Given this list of marker genes Sbf2, Fabp9, Syt2, Cyp26b1, Zfyve1, Cfl1, Rag2, Hadha, Gsdma3, Pard3, Picalm, Paqr9, Fis1, Rnf34, Plek2, Tirap, Scarb1, Appl2, Pla2g4a, Pla2g2a, Scgb1b15, Tpcn2, Hsd3b1, Svil, Apol9b, Mtm1, Gsta1, Gltpd2, Jag1, Pacsin3, Hspa2, Stam2, Nf1, Stard10 (NCBI Gene Id 56018), Traf2, Anxa9, Cyp26c1, Map1b, Osbpl8, Apoc3, Pltp, Star, Ffar2, Ing2 (inhibitor of growth family, member 2), Myo1c (NCBI Gene Id 97728), Tlr4, Cyth4, Bin1, Stard9, Bpifb2, Abca1, C2cd2l, Rufy1, Cyp4f15, Myo1b, Clint1, Asap1, Itpr2, Snx4, Ephx1, Sprr2i, Arhgap35, Ccdc88a, Esr2, Ybx2, Gramd1b, Dnm2 (NCBI Gene Id 13430), Iqgap1, Scp2 (sterol carrier protein 2, liver), Ptafr, Akr1c21, Tom1l2, Veph1, Scgb1b3, Slc9a1, Snx6, Gsdmc4, Plcb2, Hsd17b1, Blnk, Osbpl11, Apoc2, Ppara, Comp, Dnm1, Sestd1, Atp5mc3, Snx1, Hspd1, Stard8, Mark1, Thbs1, Ugt1a2, Septin5, Sprr2a3, Unc119, Arl6, Atp8b1, Scgb1b30, Apol7b, Dbt, Gstm1 (glutathione S-transferase, mu 1), Nr1h4, Wdr45b, Igtp (interferon gamma induced GTPase), Fundc2, Gbp2, Akr1b8, Syp, Sult1e1, Myof, Osbpl2, Inppl1, Igf2r, Rasgrp4, Rbp3, Unc13a, Scgb1b2 (NCBI Gene Id 57426), Btk, Ear6, Pbp2, Anxa2, Epb41, Gsdma2, Avil, Nr3c1, Arhgef5, Gstp-ps, Ly96, Wdfy1, Sh3glb1, Enthd1, Gper1, Cd81, Plekha3, Gsdme, Paqr8, Cd1d2, Lbp, Sh3gl1, Jchain, Snx10, Fnbp1, Nsfl1c, Kcnj3, Laptm4b, Prom2, Trem3, Npc2, Arhgap32, Drosha, Scgb1b27, Ghr, Dysf, Gltp, Rasa2, Dppa1, Ncf1 (neutrophil cytosolic factor 1), Dab2ip, Scube2, Rho (NCBI Gene Id 212541), Vps36, Apol7a, Tnr, Gsta5, Epn3, Tecpr1, Vdr, Pex1, Hmgcl, Adap2, Snx27, Snx2, Rara, Snx3, Adh7, Map1lc3b, Mbl2, Adh4, Rbp2, Syt6, Scgb1b7, Slc22a2, Tiam1, Ugt1a1 (UDP glucuronosyltransferase 1 family, polypeptide A1), Acadvl, Ighm, Acap2, Syt8, Ppt1, Cpne2 (copine II), Dapp1, Gstm7, Snx33, Grk5, Cln8, Gga2, Pla2g2c, Rpe65, Opn4, Vill, Myo10, Cpne9, Unc13c (unc-13 homolog C), Sec14l4, Gsdmd, Amer1, Cidea, Itpr1, Defb6, Pik3c2g, Zfyve9, Gstp2, Unc13b, Cyp4f40, Insig1, Nme2, Rasa4, Anxa4, Rnase2b, Cpne4, Stard3nl, Arap2, Apol7e, Oc90, Sgk3, Eea1, Pitpnc1, Prap1, Pld2, Gpr119, Cd1d1, Bpifb4, Epdr1, Cptp, Hsd17b10, Pitpnm1, Snap25, Cdk5r2, Arap1, Pebp1, F10, Clip3, Hspa8, Bpifa2, Selp, Anxa8, Sphk1, Fundc2b, Sh3gl3, Pgrmc1, Rapgef6, Cpne6, Gramd1a, Frmpd2, Syt7, Ffar3, Cd4, Slc38a9, Pla2g4e, Snx24, Amer3, Lyn, Sprr2e, Vil1, Atp1a1, Fchsd2, Nup62cl, Rbp1, Mag, Rbp4, Plekhf1, Tulp3, Tex2, Tec (NCBI Gene Id 21682), Fgd2, Nr5a1, Pitpnb, Bin2, Pla2g7, Shbg, Scgb1b20, Gabarapl2, Ngf, Dbil5, Apoa2, Sh3yl1, Rapgef2, Defb15, Cyp4a14, Lpar4, Apoa5, Gc, Hgs, Cpne7, Myo1e, Clec4f, Defb42, Mcoln3, Cpne1, Amph, Esrrb, Apoa1 (NCBI Gene Id 11806), Hsd3b5, Sftpd, Fzd7, Anxa3, Acbd5, Gap43, Hmgb2, Plcz1, Vcp (valosin containing protein), C2cd5, Pitpna, Fabp6, Rbsn, C3, F2, Snap91, Acbd6, Tpp1 (NCBI Gene Id 12751), Pxdc1, Oma1, Sdcbp2, Rps6kc1 (ribosomal protein S6 kinase polypeptide 1), Nfe2l1, Smo, Ninj1, Plekha4, Osbpl7, Arfip1, Tulp1, Cplx1, Spata18, Apoc2l, Psd4, Anxa1, Ninj2, Pxk, Ear1, Sidt1 (SID1 transmembrane family, member 1), Tmem199, Cyp2w1, Acadl, Snx22, Gsn, Rcsd1, Tom1l1, Snx13, Osbpl9, Stard7, Noxo1, Plekhb2, Sytl2, Krit1, Irgm2, Osbpl3, Cyp26a1 (cytochrome P450, family 26, subfamily a, polypeptide 1), Snx18, Tardbp, Hnf4a (NCBI Gene Id 15378), Tlr6, Apol9a, Or1j21, Pcyt1a, Alox8, Hsd3b8, Syt15, Pctp, Pmp2, Snx11, Id3, Kcnj1, Bpifb6, Doc2b, Uqcc3, Sytl3, Mvb12a, Arhgdia, Ear2, Gbp2b, Fabp4, Arhgap9, Actn2, Twf1 (NCBI Gene Id 19230), Bscl2, Defb3, Golph3l, Osbpl1a, Mreg, Ogt, Defb21, Mbp, Myo1g, Nr2f2, Tmem97, Defb13, Ncf4, Fermt3, Or6e1, Snx7, Cd36, Faah, Cyp4f14, Scin, Plcb1, Ttpa, Defb5, Nup35, Bad, Minar2, Sprr2a1, Ldlrap1, Apol7c, Pfn3, Vdac2, Snx31, Syt12, Golph3, Dgka, Chmp2a, Pla2g4d, Acot11, Hcn1, Sh3gl2, Cps1, Adora2a, Cpne5, Insig2, Nlrp3, Ugt1a7c, Lcn5, Ceacam2, Pfn4, Snx25, Npc1l1, Fitm2, Apoe, Anxa11, Adap1, Apol11a, Esyt3, Trpv1, Cadps, Cyth3, Rasgrp1, Tlr2, Clec4e, Rnase2a, Ear10, Apol8, Syt4, Hsd11b2, Dok7, Ugt1a9, Lpar1, Plekha5, Map3k1, Pla2g2f, Spart, Timd5, Apol6, Apob, Sytl4, Cd14, Havcr1, Deptor, Vnn1, Rufy4, Gsdmc2, Prlr, Pld1, Gbf1, Pla2g2d, Hsd3b9, Pcyt1b, Mctp2, Pram1, Ear14, Gsta13, Rora, Zranb2, Zcchc14, Plekha1, Rs1, Sprr2g, Plaat3, Abca4, Arhgap26, Agap1, Gga1, Iqgap2, Dgkb, Mtss2, Snx29, Lrat, Mppe1, Tnfaip8l3, Stard13, Cpne3, Pdia2, Prkca (protein kinase C, alpha), Osbpl10, Ucp1, Snx30, Cd55b, Acoxl, Opn5, Pirt, Fabp3, Gcdh, Bpifa1, Scap, Rlbp1, Zfyve26, Snx12, Wipi1, Bpi, Gsta2, Soat2, Prkci, Snx14, Mark2, Bcas3, Mitd1, Gpr183, Acot12 (NCBI Gene Id 74899), Epn1, Got2, Defb7, Cdipt, Gpr141, Fcgr4, Snx19, Acox1, Pon1, Syt11, Crabp1, Kcnq1, Syt13, Pnpla3, Dlc1, Psma1 (NCBI Gene Id 26440), Ceacam1, Opa1, Mbl1, Stoml2, Pla2g5, Pla2g4f (phospholipase A2, group IVF), Stard3, Crp, Capg, Commd1, Kif16b, Rabggtb, Tmem175, Ltc4s, Cyth2, Fuz, Ffar1, Prr7, Defb8, Gpaa1, Hip1r, Cideb, Zfyve16, Frmpd4, Acox2, Phlda2, Lamb1 (laminin B1), Psmb4, Defb34, Ltf, Timd4, Pgrmc2, Cln3, Iapp, Dgat1, Axl, Sdcbp, Gramd1c, Trpv4, Tom1, Ptch1, Dennd1a, Mfge8, Atp1a2, F3, Syt14, Pla2g4b, P2rx2, Plekhn1, Calb1, Ap2a2, Fabp12, Dab1, Doc2a, Acbd3, Syt17, Pex3, Mvb12b, Rorc, Twf2, Syt5, Arfip2, Jph2, Il2, Gsdma, Pla2g4c, Atp5mc2, Anxa5, Stx3, Anxa10, Tpcn1 (NCBI Gene Id 338536), Syt3, Rph3a, Otc, Nisch, Rab35, Npc1, Cert1, Snx15, Bax, Snx16, Phf12, Atp5po, Pitpnm2, Zcchc2, Paqr6, H2bc21, Apol11b, Vamp2, Gsdmc3, Serpina6, Apold1, Apol10a, Dgkg, Unc119b, Exoc7, Paqr7, Ap2m1, Coq9, Esr1, Plcd1, Ppard, Stam, Dmbt1, C8g, Pick1, Cel, Pclo, Bin3, Nup62, Mme, Mtss1, Scgb1b24, Ptgds, Fchsd1, Osbpl5, Marcks, Bpifb3, Spon2, Cpne8, Cyth1, Kcnj2, Rtn4r, Atg2a, Dab2, Dbi, Erlin1, Bltp2, Phlda3, Gga3, Atp5mc1, P2rx7, Gle1, Apoh (apolipoprotein H), Bpifc, Cd6, Trem2, Arap3, Trim72, Lpl, Phlda1, Atp13a2, Epn2, Pfn1, Prom1, Scarb2, Defb19, Kcnh1, Anxa7, Itpr3, Snx17, Pemt, Acox3, Smpd3, Wdr45, Lpar3, Fermt2, Sh3pxd2b, Psd2, Syt10, Alox5ap, Slc9a3, Inpp4b, Nr5a2, Rubcnl, Stard4, Sgip1, Cavin2, Syt1, Pask, Osbpl6, Hsd3b4, Sec14l2, Nme4, Paqr5, Tril, Iqsec1, S1pr1, Defb4, Snx21, Vdac1, Aldh1a2, Aida, Ehd3, Intu, Anxa6, Appl1, Pik3c2a, Casp4, Cd300a, Ar, Sell, Gsdmc, Mcf2l, Apba1, Racgap1, Pfn2, Osbp2, Exoc8, Pacsin1, Snx32, Scgb1b19, Serpina5, Npm1, Gpr31b, Hs1bp3, Bpifb1, Nlrp6, Apoa4, Scgb1b12, Snx8, Ugt1a8, Snx20, Clvs2, Ophn1, Arhgap44, Psd, Lamc1, Fes, Amer2, Cgas, S100g, Exoc1 (NCBI Gene Id 69940), Fabp2, Fitm1, Rxra, Cyp2r1, Cyp11b1, Fzd5, Rbp7, Vps13b, Nr3c2, Esrra, Apol10b, Pgr, Fer, Adh5, Stard6, Syt16, Sytl5, Syt9, Map1lc3a, Fabp5, Apom, Dnm1l, Cln6, Pigu, Gstp3, Timd6, Gramd2a, Sprr2d (small proline-rich protein 2D), Ffar4, Ankfy1, Gpr155, Igf1, Stard5, Washc2, Cd300lf, Camp, Dennd1c, Ugt1a10, Atg2b, Bdh1, Soat1, Esrrg, Acads, Esyt2, Manf, Tlr1, Trip10, Cd55, Numa1, Osbp, Gabarapl1, Pla2g1b, Bpifb9a, Alox15, Pdzd8, Obscn, Pparg, Gab2, Esyt1, Plekhf2, Irgm1, Alb, Snca, Chmp3, Cyp21a1, Akt1, Baiap3, Apod, Flii, Acbd7, Aldob, Cibar1, Bpifa5, Micall1, S100a13 (NCBI Gene Id 20196), Twnk, Plekha2, Pard3b, Tln1, Phb2, Bbs5, Acot7, Gas1, Carmil2, Adgrb1, Dpep1, Eci2, Gas6, Snx5, Arhgap33, Cav1, Ticam2, Nrgn, Eci3, Gpr12, Psap, Wdpcp, Pla2g10, Sptbn1, Gabarap, Cerkl, Snf8, Bpifa3, Grb7, Mttp, Clvs1, Fyb1, Gpihbp1, Cyp3a13, Trpc2, Opn3, Plekha8, Tspo2, Tns2, Cadps2, Insr, Erlin2, Fnbp1l, Hmgb1, Dennd1b, Bspry, Timd2, Lcn12, Apoc1, Wipi2, Pacsin2, Nr4a1, Hck, Rubcn, Pitpnm3 (NCBI Gene Id 327958), Crabp2, Sult2b1, Melk, Rida, Anxa13, Gstp1, Sh3pxd2a, Acadm, Fabp1, Wdfy3, Ckmt2, Mcoln1, Prex1, Zfyve19, Zfyve28, Fabp7, Baiap2l2, Lipc, Stra6, Rtn4, Ttpal, Thy1 (thymus cell antigen 1, theta), Cidec, Cyp11a1, Lama1, Snx9, Hsd11b1, Hip1, Mapkap1, Sap30l, Pla2g2e, Lancl2, Fcho2, Scgb1b10, here is a description of the gene set: Binding to a lipid. studied in species Mus musculus Mouse Gene Set: GOMF_LIPID_BINDING